The following is a description of a gene set: Regulation of Glucokinase by Glucokinase Regulatory Protein Human Gene Set: REACTOME_REGULATION_OF_GLUCOKINASE_BY_GLUCOKINASE_REGULATORY_PROTEIN studied in species Homo sapiens, and this is the list of marker genes: NUP98, NUP43, NUP210, SEH1L, NUP160, NUP205, NUP42, AAAS, POM121 (NCBI Gene Id 9883, POM121 transmembrane nucleoporin), SEC13, NUP54 (nucleoporin 54), NUP155, NUP62, GCKR, POM121C, NUP58, NUP214, NUP37, NUP93, RANBP2, GCK, NUP107, NUP35, TPR, NUP85, NUP133, RAE1, NUP88, NUP50, NDC1, NUP188, NUP153